Given this list of marker genes PRKAR1A, MSH6, RSPRY1, KRAS, FAM149B1, PDGFB, CASP10, MYC, GJB6, TGFBR2 (NCBI Gene Id 7048), SMARCE1, TOPORS, MSH2, PTCH2, TMEM216, DYNC2H1, HSPG2, PDE6D, TMEM107, MDM4, TRAF7, PMS2, EDN1, OFD1, KAT6B, FASLG, APC, KIAA0753 (NCBI Gene Id 9851), PLAG1, KIF7, KIAA0586, C2CD3, NEK1, WRAP53, MAN2C1, FGF3, WDPCP, CEP120, TCTN3, FAS, LMNA, TMEM231, GNAI3, PIK3CA, MLH1, SUFU, OCRL, WRN, NF2, TERT, AKT1, EPCAM, DDX59, PTCH1, BAP1, INTU, PMS1, SMO, GJB2, PLCB4, SMARCB1, CPLANE1, here is a description of the gene set: species: Homo sapiens Neoplasm of the oral cavity A tumor (abnormal growth of tissue) of the oral cavity. Human Gene Set: HP_NEOPLASM_OF_THE_ORAL_CAVITY